The following is a description of a gene set: Genes containing one or more binding sites for (ZBTB1) in their promoter regions (TSS -1000,+100 bp) as identified by GTRD version 20.06 ChIP-seq harmonization. species: Homo sapiens from publication Yevshin I, Sharipov R, Kolmykov S, Kondrakhin Y, Kolpakov F (PMID 30445619) Human Gene Set: ZBTB1_TARGET_GENES, and this is the list of marker genes: DYNC2I2, NEAT1, TPM3, CDK20, DLC1, LRRC37B, SELENOH, SC5D, SEMA7A, STAT6, IBA57-DT, AK2, PRKAB1, ZIC2, SMIM2-AS1, LINC00963, CLIC4, FNTA, SLC25A6, PHF3, RPL30P11, TRAPPC9, FAM8A1, RBBP4, LINC02960, VWA8-AS1, CDC42EP4, GBA1, LIG4, DCAF11, SPAG9, TSHZ2, CROCCP3, NFIA, BASP1, TASOR, TTC1, MTMR12, SLC39A13, TMEM59L, MMP16, GABARAPL1, ABHD13, TMEM237, PARP1, DLST, NR3C1 (nuclear receptor subfamily 3 group C member 1), FAM53C, NXNL2, TULP3, HOMER1, LINC02268, IBA57, ORMDL1, VPS35L, VWA8, RNFT1, GPN3, INTS12 (NCBI Gene Id 57117), CASP9, SLC39A11, NUS1P2, LINC01315, UBE3B, ARID2, TMEM248, PMS1, NRL, SMYD4, RRN3P1, RNFT1-DT, TRIB1AL, LINC00431, ZNF768, MAFK, CYC1, CACNB4, DNAJC2, PSMC2, CNTNAP2, DTWD1, EFNB2, AVPI1, C15orf39, VGLL4, PCYT1A, CRYBB2P1, POLR3H, SLC25A45, CYP51A1-AS1, ENSG00000224865, TFDP1, FRA10AC1, WDR45B, ISL2 (NCBI Gene Id 94725), PRKAA1, COX16, PRC1, FAM227B, KAT6B, SNAPC3, TM9SF2, APOLD1, TOM1L1, MTG1, RPL37, GSTCD, RPA1, ZNF592 (NCBI Gene Id 9640), KCTD5 (potassium channel tetramerization domain containing 5), ZBTB8OS, KCTD10, MIR615, UBE3C, FIGNL1